The following is a description of a gene set: studied in species Homo sapiens Any abnormality of the fontanelles (the regions covered by a thick membrane that normally ossify in the first two years of life) or the cranial sutures (the fibrous joints in which the articulating bones or cartilages of the skull are connected by sutural ligaments). Human Gene Set: HP_ABNORMAL_CRANIAL_SUTURE_FONTANELLE_MORPHOLOGY Abnormal cranial suture/fontanelle morphology, and this is the list of marker genes: GTF2H5, FOXG1, SMAD6, CYP27B1, CREB3L1, APC2, COG4, TANC2, FAM20C, BMP1 (NCBI Gene Id 649), ERCC2, ADARB1, ALG1, MEGF8, DMP1, KIF1A, MMP14, MMP23B, IYD, RBBP8, PEX6, RPS6KA3, LEMD2, PPP1CB, GP1BB, DCHS1, GNPTAB, GPX4, ATRIP, TCIRG1, INPPL1, SON, MED12 (NCBI Gene Id 9968), PTCH1, RTL1, NPHP3, PEX1, IFITM5, PIGA, TALDO1, CTSD (NCBI Gene Id 196214), AGO2, PPP2R5D (NCBI Gene Id 5528), CCDC134, CCNQ (cyclin Q), AARS1, ASXL3, LMX1B, MEG3, CARS1, USP7, HOXD13, B3GLCT, PIEZO2, SIX2 (SIX homeobox 2), DLK1, ALX4, CDC6, VAC14, PRKCZ, COL1A2, PEX12, POLR3A, SLC39A8, TENT5A, RNF125, DNA2, ANTXR1, ZIC1, OTUD5, CENPE, ASXL1, WNT5A, PPP1R21, ARX, MESD, MAF, SHPK (sedoheptulokinase), COLEC10, TGFB3, GJA8, EXTL3, HERC1, CTCF, FGFR2, GMNN (NCBI Gene Id 51053), TNFSF11, MVK, PEX11B, ELN, SLC34A3, UBR1, ETFB, NUP85, DDX3X, GCK, SMG9, CRELD1, SMAD3, GJA5 (NCBI Gene Id 2702), KCNQ1, MPLKIP, GJA1 (gap junction protein alpha 1), PEX10, MTX2, SCUBE3, HNRNPU, CREBBP, PHEX, ZNF292, HRAS, PIGQ, POLR1A, VDR, ZEB2, CHUK, CDT1, ERF, AMER1, STXBP1, ABCC8, SPECC1L, BCL11B, LTBP4, SLC35A2, FBXL4, FIG4, PDGFRB, BMP4, RNU4-2, ASPA, PCNT (pericentrin), KCNAB2, MYCN, PPFIBP1, PIGT, ALG9, FBLN5, HNF1B, H19, FBXO11, MYH3, IFT140, PEX19, ALPL, DDX6, RNU12, VARS1, IL11RA, POLA1, ATP6V1A, DPH2, ACE, SLC5A5, LRP5, SEC24C, KCNJ11, RTTN, KRT5, ORC4, ARVCF, FGFR1, CHD5, FKBP10, ADAMTS2, CWC27, NSD1, LHX4, PRKG2, ENPP1 (ectonucleotide pyrophosphatase/phosphodiesterase 1), CBFB, NFIX, DNMT3A, PYCR1, CDKN1C, DDR2, DPF2, KPTN, TBCK, TMCO1, DSE, ZSWIM6, B4GALT7, NSMCE3, ZNF462, KRAS, SKI, AIFM1, ETFDH, RSPRY1, PEX13, RPS19, BICRA, B3GALT6 (NCBI Gene Id 126792), PEX26, PLK4, KANSL1, TRPV6, ATP6V0A2, FLNA, DPYSL5, PPP2R1A, EXOC8, COL11A2, PDX1, ORC6, H4C9, COX5A, DVL1, KLF1, ETFA, NKX2-5, ATIC, SH2B1, HUWE1, GNPAT (glyceronephosphate O-acyltransferase), CDK8, AHDC1, CRTAP, MAPK1, ARID2, ERCC3, NUP188, KDELR2 (NCBI Gene Id 11014), ERCC5, PEX14, WT1, AGTR1, RNU4ATAC (RNA, U4atac small nuclear), H3-3B, RAB23, ERI1, GLI3 (GLI family zinc finger 3), TARS1, ERCC6, TRAIP, TGFB2, PEX3, COG8, GRB10, KAT6A, FAM111A, KCNQ1OT1, CCBE1, INS, GABRD, ERMARD (NCBI Gene Id 55780), IFT43, DUOXA2, VPS35L, KIF7, KLHL40, INTU, MID1, PLAGL1, KDM4B, MSX2, NSUN2, SEC23A, GLI2, EP300, CHST3, CAV1, ATP7A, NLRP3, CEP57, CEP120, LTBP1, SOX9, SLC25A24, PRIM1, ERCC1, FREM1, REN, PCDHGC4, ADAMTS3, EIF4A2, POGZ, CDH11, ATR, ACTG1, PRDM16, HYMAI, RETREG1, JMJD1C, TPO, DUOX2, DDB1, HIRA, IFT52, UBE4B, SLC4A10 (solute carrier family 4 member 10), LRP2, B3GAT3, HESX1, RUNX2, TOMM7, NCAPG2, PEX16, ZMPSTE24, RAC3, NFASC, MTOR, ORC1, LMOD3, SH3PXD2B, TBCE, LMNA, RNF113A, HNRNPK, SEC24D, WDR35, MPDU1, WDR19 (WD repeat domain 19), ATP6V1E1, SMC3, DEPDC5, MASP1, THRA, ROR2, YY1, BMPER, NKX2-1, LHX3, NFIA, ATP6V1B2, PAM16, GLIS3, DICER1, SPTBN1, COMT, HPGD, CHD6, FGFR3, ADSL, NEB, P3H1, SMAD2, UBAP2L, RREB1, NEPRO, SPEN, COLEC11, PURA, TMEM38B, KDM6A, TMEM216, ALDH18A1, AASS, UFD1, ZFX, CDC45, HSPG2, KRT14, EFNB1, PEX5, CHST14, SP7, ATRX, TCF12, PDPN, EBF3, PSAT1, SETBP1, CLCN7, KLHL41, BPNT2, GPC3, RBM10, LIG4, SLC2A10, WASHC5 (WASH complex subunit 5), GH1, GNPNAT1, PTDSS1, IL6ST, DONSON, ZNF699, TG, TLK2, TBX1, TGFBR2, PPP3CA, IPO8, NDUFAF3, PIGO (NCBI Gene Id 84720), INTS11, KMT2D, ACTB (NCBI Gene Id 60), SMO, AKT1, IFT122, SLC26A4, ANKRD11, STAT3, CHD4, CAMSAP1, GPC6, CCDC22, GORAB, NOTCH2, SCN9A, HDAC4, RERE, HSD17B4, SLC25A19, ALG8, PPIB, LHX1, POU1F1, NOTCH3 (NCBI Gene Id 791), NSRP1, TRAF7, POR, FBN1, TBC1D24, TCOF1, PLOD2, FLNB, SLC12A6, PEX2, GPC4, COL1A1, ESCO2, SETD1A, GTF2E2, NAA10, PCGF2, DIAPH1, MMP2, SC5D, KDM5B, CTSK, TWIST1, SRCAP, PROP1, MAN2B1, ACTA1, CASZ1, TGFBR1, P4HB, SCARF2, TOGARAM1, CLCN3, CYP26B1, SNX10, ADAMTSL1, WNK1, LUZP1, CEP152, SMARCD1, TSHB, NEK1, NARS2, COL11A1, IGF2, FAT4, TAPT1, FOXE1, WBP4, EBP, DPH1, BANF1, MAP3K7, RECQL4, AFF4, CYP2R1, MAP1B, AGT, NDE1, PAX8, TSHR, IRX5 (NCBI Gene Id 10265)